The following is a description of a gene set: Genes up-regulated in follicular B cells versus those stimulated with anti-IgM and CD40 for 6h. To obtain insight into the genetic basis of the increase of functional activity of memory B cells over time, we compared the gene expression profiles of day 7 and day 40 NP-specific/IgG1 memory B cells, GC B cells and plasma cells in immunized WT mice and naïve B cells, before and after activation in vitro. species: Homo sapiens Human Gene Set: GSE11961_UNSTIM_VS_ANTI_IGM_AND_CD40_STIM_6H_FOLLICULAR_BCELL_UP from publication Kaji T, Ishige A, Hikida M, Taka J, Hijikata A, Kubo M, Nagashima T, Takahashi Y, Kurosaki T, Okada M, Ohara O, Rajewsky K, Takemori T (PMID 23027924), and this is the list of marker genes: APIP, TACC3, PSMD11, SH3BGRL, SLC15A3, TULP4, MREG, CALR, NAA40 (N-alpha-acetyltransferase 40, NatD catalytic subunit), KRTAP4-12, PREX1, IFITM5, RAD54B, CSRP2, CTPS1, BMP2K, MMP20, INTS12, CDH23, NDC80, XBP1, BCL2L13, VAV3, TUBE1, FANCD2, RIN3, PRRC1, ITGAX, HASPIN, NCAPD2, ASPN, CEP55, CENPW, MS4A15, TIMELESS (NCBI Gene Id 8914), ADGRL4 (adhesion G protein-coupled receptor L4), TXN, PEX14, FBXO5, NIBAN2, HEMGN, LZIC, THBS1, TJP2, ARL5A, PAH, COPRS, KRT2, NRG3, RASGEF1B, TMEM51 (transmembrane protein 51), ACACA, GARIN1B, KIF23, SLAMF7, TIPIN, GEM, NUDT12, TMBIM4, PTPRC, RRBP1, NRARP, APOBR, MAPK6, JUND, PHACTR3, PSMA1, CERS6, TYMS, METRNL, CEBPD, TBC1D7, DENND2B, NELL1, DCLK2, LGALS1, KLF10, SEMA6D, ACOT7, NUF2, CA2, JARID2, MDM2, E2F2, OSBPL3, NKG7, SGO1, MYADM (NCBI Gene Id 91663), ARMCX4, ANKUB1, RNF43, SGCE, GNGT1, AGA (aspartylglucosaminidase), SNRPD1, CD244, CDC25A, DTNBP1, AHR (aryl hydrocarbon receptor), CENPV, TP53INP2, DRC12, FBXW12, CBS (NCBI Gene Id 875), MLKL, GEMIN6, ECHDC3, TXNDC8, GNPTAB, EMP1, DLGAP5, SYNE3, ASTN1, ZGRF1, OLFM1, DDX1, REPIN1, AGTPBP1, PLOD2, CHIC1, BORA, CARNMT1, VWA8 (NCBI Gene Id 23078), SUCO, ADSS1, PASK, KIFC1, TRIM36, YBX3, MOB3B, FKBP1A, SYN1, ZFYVE21, RPUSD1, TRPM3, ESD, PBK, TTLL12, EMILIN2, RUNX2, DPP10, CP, SLC2A6, SLC25A39, KLRC3, LYN, ZNF808, OTUD7B, NAPSA, CXCL17, SMC5, CTNNA1, B3GNT7, DRAM1, ERCC6L (ERCC excision repair 6 like, spindle assembly checkpoint helicase), COL4A2, GCNT1, KCTD11, SH2D1B, PFN1, WNK3, LMO4, PKD2, ANKRD24 (NCBI Gene Id 170961), PCYT1A, PDZK1IP1, CAD, C15orf48, ORC6, MEST, CD300LB, KCNK10, FCER1G, MRE11, HIRIP3, STMN1, PCNA, SFTPA1, NRSN2, GATA3, PRR11, MRAS, PLEKHF1, TNFRSF21, EED, CENPL, MCU, TXNRD1, PSMA5, PDSS1, BIRC6, CNIH4, IRF8, CEMIP2, TSPOAP1, MTFR2, CBFA2T3, ERG, SNX13, SEMA4C